Given this list of marker genes RPS3, RPS27, RPS20, RPS15, RPS5, RPS26, RPS15A (NCBI Gene Id 6210), RPS29, RPS19, EEF1A1, RPS28, RPS27L, FAU, RPS4Y1, RPS3A, HNRNPA1, RPSA (ribosomal protein SA), RPS14, RPS25, RPS6, RPS4X, RPS8, RPS12, RPS4Y2, RPS27A, RPS24, RPS13, RPS17, RPS16, RPS21, RPS2, RPS11, RPS10, RPS9, RPS7, RPS18, RPS23, here is a description of the gene set: SARS-CoV-1 modulates host translation machinery Human Gene Set: REACTOME_SARS_COV_1_MODULATES_HOST_TRANSLATION_MACHINERY species: Homo sapiens